Given this list of marker genes Tardbp, Rnpc3, Prpf8, Rbm24, Rbm20, Rbpms, Sox9, Ep300, Rbm7, Hnrnpl, Elavl4, Rbm4, Rbm41, Hnrnpa2b1, here is a description of the gene set: species: Mus musculus Mouse Gene Set: GOMF_PRE_MRNA_INTRONIC_BINDING Binding to an intronic sequence of a pre-messenger RNA (pre-mRNA).